The following is a description of a gene set: The presence of a dilated inner part of external acoustic meatus. species: Homo sapiens Human Gene Set: HP_DILATATED_INTERNAL_AUDITORY_CANAL Dilatated internal auditory canal, and this is the list of marker genes: GJB6, EYA1, GJB2, SIX1, POU3F4